The following is a description of a gene set: Any process that activates, maintains or increases the frequency, rate or extent of the directed movement of amino acids into, out of or within a cell, or between cells, by means of some agent such as a transporter or pore. species: Mus musculus Mouse Gene Set: GOBP_POSITIVE_REGULATION_OF_AMINO_ACID_TRANSPORT, and this is the list of marker genes: Grik1, Grin2b, Syt4, Arl6ip1, Agt, P2rx7, Stxbp1, Arhgef11, Slc38a3, Itgb1, Kmo, Slc17a8, Ntsr1, Dpysl2, Adora2a, Slc38a1, Gabbr1, Trh, Nr3c1, Slc7a5, Dtnbp1, Htr2c, Psen1, Ace2, Abat, Rab3gap1, Cltrn, Avp, Avpr1a, Slc12a2, Slc6a1, Cck, Htr6, Slc36a2